The following is a description of a gene set: Genes up-regulated in MCF-7 cells (breast cancer) by overexpression of CMYB off adenovirus vector. Human Gene Set: LIU_CMYB_TARGETS_UP studied in species Homo sapiens from publication Liu F, Lei W, O'Rourke JP, Ness SA (PMID 16205643) The v-Myb oncoprotein encoded by Avian Myeloblastosis Virus is highly oncogenic, induces leukemias in chickens and mice and transforms immature hematopoietic cells in vitro. The v-Myb protein is a mutated and truncated version of c-Myb, a DNA-binding transcription factor expressed in many cell types that is essential for normal hematopoiesis. Previous studies suggested that two types of differences, DNA binding domain mutations and the deletion of a C-terminal negative regulatory domain were important for increasing the transforming activity of v-Myb. Here, we combined structure-function studies of the v-Myb and c-Myb proteins with unbiased microarray-based transcription assays to compare the transcriptional specificities of the two proteins. In human cells, the v-Myb and c-Myb proteins displayed strikingly different activities and regulated overlapping, but largely distinct sets of target genes. Each type of mutation that distinguished v-Myb from c-Myb, including the N- and C-terminal deletions, DNA binding domain changes and mutations in the transcriptional activation domain, affected different sets of target genes and contributed to the different activities of c-Myb and v-Myb. The results suggest that v-Myb is not just a de-repressed version of c-Myb. Instead, it is a distinct transcriptional regulator with a unique set of activities., and this is the list of marker genes: WDR44, LNPEP, WDR46, TMEM30B, NQO1, CA12, GREB1, WASHC3, AK4, ADD3, DLG1, MED4, RETREG2, CA8, CITED2, VRK1, ZNF318, USP25, ICA1, ACOT7, TIPARP, RPL23AP1, PTBP3, SRD5A1, SAT1, GLRX, ABCC3, RNGTT, PDCD4, MARK2, ZNF395, AKAP1, EFHD1, LYPD1, NUMA1, BNIP3L, PRLR, HPCAL1, NUCB2, CDC42EP1, SLC10A3, SLCO3A1, IMPA2, MT1F, DHRS2, CALML5, RAB11FIP1, RAB11B, THAP9-AS1, CRIM1, TACC2, NUDT1, TOB1 (NCBI Gene Id 10140), SLC1A4, OVOL2, LITAF, ASRGL1, YKT6, INSIG1, FOSL2, HIGD2A, STARD5, CTNNAL1, MARCHF5, FABP5, PCOLCE2, HBA1, JAG1 (jagged canonical Notch ligand 1), H1-10, HSPA12A, NCOA1, BSPRY, PDK2, EZH2, MT1H (metallothionein 1H), ISYNA1, PRAF2, ETFDH, HYOU1, SERPINA3, PCTP, CXCR4, SPG11, KRT16, SLC31A2, GMCL1 (NCBI Gene Id 64395), NMRK1, PHLPP1, MMD, STK17A, NOSIP, ESYT1, ANKRA2, ASS1, SAP30, SOX9, PEBP1, TGIF1 (NCBI Gene Id 91941), SIK1, MPHOSPH9, IGFBP4, PPM1E, SPG7, ISG20, IL17RB, PIM2, TGFBI, FHL2, SAC3D1, KLHDC2, DNAJB9, ECE1, ABTB2, CRISPLD2, PPDPF, ANP32E, MT2A, PACS2, CTNS, PXDN (peroxidasin), ARRB2, GMNN, IDS, PLCXD1, CSGALNACT2, TNKS2, DNAJB5, SATB2, TSPAN1, MAP1LC3B, MT1X, HECTD4, TP53I11, PRKAR2B, AGAP1, MARCHF3, NAGPA, ALDH7A1, RPS6KA2, CASP6, ARL4C, KCNS3, ICAM3 (NCBI Gene Id 3385), ZP3, LHX6, ZER1, MYO10, DUSP9, GDPD3, RRM2, SH2D4A, MAPK3, GSTM3, EPHX1, SERINC5, NAB2, PYGB, TRPV2, RBM47, ST6GALNAC2, EMP3, AGA, OAT